Given this list of marker genes Trp53, Abl1, Rnf8, Eya1, Pias4, Smarca5, Mapk8, H4c16, Chek2, Sumo1, Eya4, H2bc22, Nbn, Nsd2, Rps27a, H2bc14, H4c8, Kpna2 (karyopherin subunit alpha 2), H2bc3 (NCBI Gene Id 319178), H4c1, Ppp5c, Abraxas1, Brcc3, H2bc21, H3f4, Mdc1, H2bc8, Babam1, H4c2, H2bc6, Uba52, H4c18, Ube2n, H2bc26, H2bc23, H2bc24, Kdm4a, Baz1b, H2bc4, Eya3, H4c12, Mre11a, Brca1, H2bc11, H2bc9, H4c9, Uimc1, Kpna2rt, Apbb1, Bard1, Bap1 (NCBI Gene Id 69465), H4c17, Kdm4b, Ube2v2, H4c4, H2bc15, Uba52rt, Atm, H4c6, H2bc1, H2bc7, Babam2, H2ax, H4c11, Ube2i, Herc2, Trp53bp1, Ubxn1, H4c3, Ubb, Ubc, Eya2, Rnf168 (NCBI Gene Id 70238), H2bc13, H4c14, Kat5, Rad50, H2bc12, here is a description of the gene set: species: Mus musculus DNA Double Strand Break Response Mouse Gene Set: REACTOME_DNA_DOUBLE_STRAND_BREAK_RESPONSE